Given this list of marker genes IL33, GRN, TREM2, TYROBP, CX3CR1, here is a description of the gene set: The change in morphology and behavior of a microglial cell resulting from exposure to a cytokine, chemokine, cellular ligand, or soluble factor, leading to the initiation or perpetuation of an immune response. Human Gene Set: GOBP_MICROGLIAL_CELL_ACTIVATION_INVOLVED_IN_IMMUNE_RESPONSE species: Homo sapiens